The following is a description of a gene set: from publication Chen Y, Wang X (PMID 31504780) studied in species Homo sapiens Human Gene Set: MIR6506_5P Genes predicted to be targets of miRBase v22 microRNA hsa-miR-6506-5p in miRDB v6.0 with MirTarget v4 prediction scores > 80 (high confidence targets)., and this is the list of marker genes: ODF2L, ARHGEF6, PTAFR, BOC (BOC cell adhesion associated, oncogene regulated), WDR59, MAVS, SUSD5, CALD1, TMEM183A, TIMM50, TMPO, YWHAG, MTCL2, FNDC9, TMEM183BP, AGAP1, GLCE, CTNS, KLB, GPD2, YME1L1, MDM1, ZNF721, NFATC2, URM1, COPG2, LETM2, WWC2 (WW and C2 domain containing 2), KIAA1328, LASP1, TCN1, MYCL, ABHD18 (NCBI Gene Id 80167), SPRYD4, SPATS2, TSPYL6, ITGA1, ATXN3, C19orf18, LINC02898, PTP4A2, TMEM37, AVL9, CAMK1D, NR3C1, ABHD2, CPEB1, PATE2, CCNT1, POU4F1, SUDS3, STON2, TRMT10C, PRDM5 (PR/SET domain 5), CORO1C, PLEKHG4B, MASP1, ZNF577, CACNA2D1, DOCK5, ANAPC16, TCEANC2, MGARP, SLC7A14, LRRC74B, LGI1, SLC43A2, VCF2, HIP1, WDFY1, COL4A3, C11orf58, GPATCH8, PLA2R1, SPOCK1, FGF11, PPIC, GGT7, WNT7B, CYP20A1, ORAI2, NLGN1, PRR11, AAK1, ROCK2, ESRP1, CYFIP2, CENPU, KCNMA1, OPA3, VLDLR, MTX3, SLC25A23, ETS1, NAA50, CELF4, METTL21A, TRIM49D1, CACNA1E, TOE1